Given this list of marker genes SRC, FCGR2B, CD300A, MIR125A, CLEC12A, GRN, PTPN6, PTPN11, here is a description of the gene set: Human Gene Set: GOBP_NEGATIVE_REGULATION_OF_NEUTROPHIL_ACTIVATION studied in species Homo sapiens Any process that stops, prevents or reduces the frequency, rate or extent of neutrophil activation.